Given this list of marker genes ZDHHC7, SLC27A4, SLC2A4, SLC27A1, TRARG1, SGCB, here is a description of the gene set: studied in species Homo sapiens The directed movement of the hexose monosaccharide glucose into a cell as a result of an insulin stimulus. Human Gene Set: GOBP_GLUCOSE_IMPORT_IN_RESPONSE_TO_INSULIN_STIMULUS